The following is a description of a gene set: Human Gene Set: GOBP_L_LYSINE_TRANSPORT The directed movement of a L-lysine into, out of or within a cell, or between cells, by means of some agent such as a transporter or pore. studied in species Homo sapiens, and this is the list of marker genes: SLC7A3, SLC7A1, SLC25A29, SLC7A2, SLC7A6, SLC66A1LP, SLC25A15, SLC66A1, SLC25A2